The following is a description of a gene set: species: Mus musculus Any process that regulates translation occurring at the postsynapse. Mouse Gene Set: GOBP_REGULATION_OF_TRANSLATION_AT_POSTSYNAPSE, and this is the list of marker genes: Eif4a3l1, Eif4a3, Eif4e, Cyfip1, Tent2, Elavl4, Ngdn, Fmr1 (NCBI Gene Id 207836), Eif4a3l2, Eef2k